Given this list of marker genes BLOC1S6, ITGA2B, GP9, RASGRP2, BLOC1S5, ITGB3, ACTN1, FLI1, MYH9, IKZF5, DIAPH1, GFI1B, PLA2G4A, BLOC1S3, GP6, GATA1, DTNBP1, GUCY1A1, ABCG8, P2RY12, RUNX1, THPO, LCP2, TBXA2R, VWF, AP3B1, CALR, GP1BA, NBEAL2, TPM4, GP1BB, SH2B3, EPHB2, HPS5, HPS6, PLAU, KCNJ1, TUBB1, CISD2, MGAT2, HPS3, here is a description of the gene set: An abnormality in the rate and degree to which platelets aggregate after the addition of an agonist that stimulates platelet clumping. Platelet aggregation is measured using aggregometer to measure the optical density of platelet-rich plasma, whereby platelet aggregation causes the plasma to become more transparent. Abnormal platelet aggregation species: Homo sapiens Human Gene Set: HP_ABNORMAL_PLATELET_AGGREGATION